Given this list of marker genes SPAG5, PAICS, TTK, RACGAP1, MRPL39 (mitochondrial ribosomal protein L39), BUB1B, CSE1L, HELLS, PCNA, AURKA, NASP, CCNB2, UBE2C, CDCA8, TOP2A, NDC80 (NCBI Gene Id 10403), CDC20, KIF11, ASF1B, TCP1 (NCBI Gene Id 6950), RRM1, CEP55, TYMS, GINS1, BUB1, ZWINT, MELK, KIF14, ASPM, FANCI, POLD1, MCM2, NUP205, AURKB, MCM3, CENPM, PLK1, SMC4, ESPL1, GMNN, PA2G4, NCAPD2, CCNA2, MCM4, LMNB1, KIF20A, HMMR, RRM2, HJURP, here is a description of the gene set: Neighborhood of BUB1B BUB1 budding uninhibited by benzimidazoles 1 homolog beta (yeast) in the GNF2 expression compendium Human Gene Set: GNF2_BUB1B studied in species Homo sapiens Neighborhood of BUB1B